Given this list of marker genes IRGM, TXK, MED1, NLRC5, PARP9, HPX, here is a description of the gene set: Any process that increases the rate, frequency or extent of a response to type II interferon (interferon-gamma). Response to interferon gamma is a change in state or activity of a cell or an organism (in terms of movement, secretion, enzyme production, gene expression, etc.) as a result of an interferon-gamma stimulus. Human Gene Set: GOBP_POSITIVE_REGULATION_OF_RESPONSE_TO_TYPE_II_INTERFERON studied in species Homo sapiens